Given this list of marker genes ZC3H12A (NCBI Gene Id 80149), WIPI1, TSC2, EIF2S1, SESN1, UPP1, EHMT2, ASNS, SP7, RNF167, RALB, SUV39H1, SP1, MYH13, GAS6, PAK4, MAPK1, STK24, MICU1, SEH1L, WDR59, LRRK2, WDR24, FOXO3, SREBF2, NPRL3, UCP2, GCGR, AKR1C3, FAS, SESN3, PAK3, KLF10, SLC38A2, CAV1, WDR45B, PAK1, SIRT1, FBXO22, PLIN2, VPS41, TTC5, YWHAZ, AMBRA1 (autophagy and beclin 1 regulator 1), ATXN3, MYBBP1A, SZT2, MTMR3, RRP8, BECN1, FOXO1, ATF3, PCSK9, NUAK2, WNT2B, KPTN, CHKA, PRKCH, WNT4, RNF152, GABARAP, MAP1LC3B, SLC34A1, DEPDC5, GABARAPL2, IMPACT, YME1L1, GPR155, CASTOR1, XPR1, ATG7, PPARA, COMT, PAK5, PDK4, CARTPT, SREBF1, BECN2, PRKAG1, GABARAPL3, RRAGC, CLEC16A, ELAPOR1, GCN1, LARS1, GABARAPL1, ZFYVE1, SESN2, RRAGB, FOXA3, MAP1LC3B2, PPM1D, PIK3R4, PRKAG3, BMPR2, WNT9B, MFSD2A, SFRP1, WDR45, TBL2, CDKN1A, TP53, ITFG2, IFI16, KAT5, HIGD1A, NPRL2, TNRC6A, PCK1, TNFRSF11A, RPTOR, ALB, SAMTOR, PLIN3, SH3GLB1, HRK, DNAJC15, HSPA8, SMDT1, RRAGD, EIF2AK2, SLC39A4, STK26, KRT20, JMY, EIF2AK3, PIK3C2B, HSPA5, ATF4, TBC1D7, MTOR, FADS1, SAR1B, KICS2, PRKAG2, TSC1, FNIP1, YWHAG, SRD5A1, FLCN (folliculin), BHLHA15, RIPOR1, SAR1A, XBP1, PICK1, NFE2L2, MYOD1, PRKAA1, HNRNPA1, ATF2, MCU, MAP1LC3A, MIOS, NUPR2, GAS2L1, SLC38A3, MAPK8, PIK3C3, BCL2, FOS, RRAGA (NCBI Gene Id 115960), ATG5, PAK2, WIPI2, LAMP2, SLC2A1, WRN, MAP3K5, DSC2, PAK6, PMAIP1, EIF2AK4, CADPS2, PRKD1, BGLAP, GBA1, CPEB4, MAPK3, ATG14 (autophagy related 14), PRKAA2, INHBB, SLC7A5, TFEB, TRIM32, MAP1LC3C, SLC39A5, USP33, GLUL, here is a description of the gene set: studied in species Homo sapiens Human Gene Set: GOBP_CELLULAR_RESPONSE_TO_STARVATION Any process that results in a change in state or activity of a cell (in terms of movement, secretion, enzyme production, gene expression, etc.) as a result of deprivation of nourishment.